The following is a description of a gene set: species: Homo sapiens Human Gene Set: GOBP_REGULATION_OF_CELL_DIFFERENTIATION Any process that modulates the frequency, rate or extent of cell differentiation, the process in which relatively unspecialized cells acquire specialized structural and functional features., and this is the list of marker genes: MME, WIF1, SLC45A3, ABCB10, ACTL6B, MEDAG, GNB3, MTA3, NUMA1, RFLNB, DDRGK1, NKX2-5, JDP2, LOXL2, PNP, CAPRIN1, NEUROD1, GPS2, MIR573, GDPD2, MT3, TSPO (NCBI Gene Id 706), HGF, BNIP2, ZDHHC21, PRAMEF26, KLF4, HES2, HDAC9, EPHB1, PRKX, CLIC1, PRUNE1, TNFRSF12A, RBPMS2, UCMA, BCL7B, PRAMEF4, BMPR1A, MIR3648-1, NR1D2, HIF1AN, OVOL2, BOC, LAMB2, CLDN5, HSPA1A, NFE2L1, ETV4, JUNB, LIMD1, VNN1, ATF4, MAP2K2, SLC6A4, CDKN1B, CDH5, ARID1A, PLAAT4, IL23A, ANXA2, NPHP3, TRIM16, PTBP1, LPAR3, SIRT6, ALOX5, MIB1, FSHB, XDH, IL1B, POU4F1, SRRT, MACROH2A2, PAEP, TREM2, DRAXIN, SOCS2, BTG1, AGT, ADRA2B, NANOG (NCBI Gene Id 92937), MAP2K1, GAS6, PRAMEF15, CDH4, SUCO, SYT4, ARID2, RTN4, FBN2, NKX3-2, SPAG9, CREB1, TNFRSF11A, GLUL, PTH, MIR130A, MIR138-1, FOXA2 (forkhead box A2), SART1, DKKL1, LRP5, BRINP2, EFNB3, LRRC8A, FOS, ANP32B, PIAS3, ABCB1, DMRTA2, LNPK, INHA, PITHD1, FXR1, OPA1, PDPN, CCR1, CAV1, ALX1, NEUROD2, ZNF536, PSEN1, PRAMEF9, SOX2, CR1, RNF41, PWP1, RNF112, ABCA12, H4C1, SLC7A10, FOXG1, KIF14, SAV1, CHD7, HES5, SPINK5, SMAD4, SFRP4, ZFHX3, WEE2, EDNRB, CHODL (NCBI Gene Id 84535), MAMSTR, LRP4, KLK6, PIK3R1, SMAD6, SIK1, ESRRB, LGALS1, BRINP3, METTL14, PPP2R3C, EGR2, DPYSL5, PLA2G5 (phospholipase A2 group V), TENM4, MYOG, ZNF488, S1PR3, SOX9, ISL1, MIR19A, EPO, EDN3, SPINT1, CDK5 (cyclin dependent kinase 5), ENG, CTR9, BRD2, NBL1, RB1, CD80, RPL3L (ribosomal protein L3 like), DPF2, FOXO4, LDLR, HMGB3, MAP3K13, E2F1, P4HTM, FBXW8, NKX2-2, SUZ12, RECK, GREM1, MTA1, ROCK2, TGFB2, SMARCA2, FSHR, AGTR1, CDK12, DDR2, N4BP2L2, GCNT2, MIR107, CCDC85B, MYC, ADIPOQ, SMYD1, BCL7C, F11R, FRZB, DACT3, RORA, SERPINE2, GPC1, IL7, ITCH, FOXP3, DCT, BLOC1S5, GSK3B, ZC3H12A, SMARCE1, TRPC5, SEMA3G, H4C12, MIR15B, TMEM100, SOX1, MIR204, NPPC, MIR150 (NCBI Gene Id 406942), TESPA1, CSF3R, CITED1, SOX3, BMP6, NEUROG3, NLRP3, NME2, STK11, CYP26B1, ZNF16, TBX5, TFAP2B, HTR2A, NACA, FSTL3, USF3, FUOM, WNT3A, SOD1, SLITRK1, LRG1, BRPF1, PLXNA3, PTN, EIF4G1, PSG9, NPR2, MIR146A, INS, ADAMTS7, YAP1, SFN, BNC1, SMYD5, IST1, CDKN2A, CASZ1, FEZF1, LTF, DIXDC1, WNT5A, CAPN3, PARP2, BCL6, PTPRS, ACVR2B, SERPINF2, MIR106A, PRAME, PDE3A, SLC9B2, MIR214, RASGRP1, CTNNBIP1, ZBTB16, SLAMF8, SKI, TBC1D24, FGFR1, MEGF10, CELA1, TRIO, MAN2A1, MIR34A, PI16, CXCL12, CYP27B1, ITGB3, PRMT6 (protein arginine methyltransferase 6), RBBP4, ARRB2, HPN, DDX6, CIB1, WDFY2, CCL3, RASSF2, PRAMEF18, TNF, SOX4, CARM1, UQCC2, EEF2K (NCBI Gene Id 29904), MMP11, CDKL5, AXL, CTDP1, TGIF2, VSX2 (visual system homeobox 2), BMP7, TCIRG1, L3MBTL1, FES, CX3CR1, HSPA9, FRS2, TLR9, ADGRV1, RFX3, TMEM98 (NCBI Gene Id 26022), PRAMEF7, ETS1, SLIT2, HSPA1B, NUMB, MTOR, FGF8 (NCBI Gene Id 2253, fibroblast growth factor 8), LIG4 (NCBI Gene Id 3981), BATF, MYOD1, MIR19B1, MYCN, TNFRSF1B, LRP2, GDF5, PPP1R13L, CHRD, PRAMEF10, TGFB3, PDCD4, ZFPM2, PTPRD, MSTN, CDON, ROBO1, ARHGEF2, IGFBP3, CCN6, IL21, TFAP2A, TP73, IGFBP5, SOCS1, CTH, PRKD1, STAU2, SASH3, MIR99B, FLCN, GRN, HSF1, MIR185 (NCBI Gene Id 406961), PLCB1, NOTCH4, KLF10, GDF7, PAF1, TRIM58, LPL, NFKBIA, COL5A2, PTEN, OCSTAMP, WNT7B, NR5A2, FBN1, HLTF, TARBP2, BMP4, TUNAR, POU3F2, ZEB1, MIR424, PIK3R6, SCUBE3, PRAMEF13, FCGR2B (NCBI Gene Id 2213), MALT1, TLX2, LHX2, IL17A, MIR1-1, FOXJ1, CCL8 (NCBI Gene Id 96488), TGFB1I1, HAND2, NFE2L2, TOB2, KRT84, NR6A1, MEAF6, GPRC5B, LTA (NCBI Gene Id 4049), FANCD2, DSPP, PAX8, CCN3, RUNX2, SMAD5, SPRR5, RGS14, STAT5B, BLTP1, MIR9-1, AJAP1, FBXO7, NRARP, H4C15 (NCBI Gene Id 724021), NTN1, TNR, MPL, IL12RB1, TP53 (tumor protein p53), TTBK1, GPER1, TTPA, EFEMP1, CDS1, RHOA, RAB21, MIR511, MYCL, DHX36, PRAMEF5, RC3H1, IL27, CNOT4, CCDC3, ZNF703, ATOH8, BMP10, GDI1, LTBP3, PRAMEF2, IQCB1, SORT1, STAT3, STAT5A, GJA1, SOS2, LBX1, LILRB3, CCN5, SNAI2, CARTPT, TMPRSS12, ING5, CLDN18, IFNL1, BRAF, PGLYRP2, IFNB1, MTCH2, MDK, MIR17, FGF20, GLG1 (golgi glycoprotein 1), PRKCZ (protein kinase C zeta), PRAMEF19, CDH1, RND2 (Rho family GTPase 2), LGALS3, STK3, ZMIZ1, MIXL1, PHOX2B, NEDD9, ZFHX2, PRDM1, MIR200C, CUX2, CDK9, SOCS5, GDF6, FGF10 (fibroblast growth factor 10), SPI1 (Spi-1 proto-oncogene), ACVR1, OLIG2, CRP, TOMM70, PUS7, CUL7, SIX2 (SIX homeobox 2), GLI3, ACTB, NRG1, MIR17HG, PBX1, PIEZO1, RPS6KA3, KAT6B, RCOR1, RORC, AMIGO1, ITGAV, IL4I1, ABL1, RAC1, TRPV4, LRRC17, SRSF6, SLC4A2, MEX3C, MYSM1, DYNLT1, ANAPC2, DRD2, TRIM11, RIPK1, TCF3, NGF, GDF3, CRTAM, STK25, DMD, PLEKHB2, EIF2AK4, MIR495, TRPV2, SOX8 (NCBI Gene Id 30812), KHDC3L (NCBI Gene Id 154288), OR10J5, ZFP36L2, ESRP1 (NCBI Gene Id 54845), TNFSF4, NFATC1, CLEC7A, SULT2B1, CSF2, IFITM1, ZAP70, MIR103A1, H4C3, DDX5, APOB, HDAC5, BMP8B, TWF2, ADRA2C, POR, H4C13, NEUROD4, SPOCK2, GPR65, BBS12, FOXA1, SDHAF2, NELL1, LOX, PRKACA, HCLS1, MAPK11, RARA, APLF, ZFP36 (ZFP36 ring finger protein), ISL2, TWIST2, THPO, FBXO11, VEGFC, CBFB, ETV5, FZD3, BCL2, MIR137, MIR22, PPP1CC, DSG2, NEUROG1, DAG1, FZD1, SHANK3, BTN2A2, MIR181A2, CDK5R1, MIR93, ADGRA2, SOX17, PTGS2, ADIRF, TGFBR2, GDF11, RGS4, NPTN, SMARCD3, IAPP, JUND, MIR20A, PLA2G10, SOCS3, TGIF1, CEBPD, RBM38, SIN3A, SEMA4F, TSC22D1, TCF15, RGMA, GDF2, CDX2, RELN, BTG2, MAP1B, BCL6B (BCL6B transcription repressor, NCBI Gene Id 7613), CDK5RAP2, TRIB1, IL2RG, DTX1, ADM, CAMK2B, TERT, MIR342, PRAMEF20, SETD1A, HOXA7, FOSL2, DLL4, PLA2G2A, PROC, MMD, MIR206, SERPINB3, HLA-DRA, RC3H2, ZBTB7B, MEF2C, TAF8, WNT1, PKP1, TRIM72, C1QL4, RHEB, ZBED6, SORL1, METRNL, ITPKA, FOXP1, PLPP7, ANKLE1 (ankyrin repeat and LEM domain containing 1), DUSP15, HDAC1, DROSHA, HLA-DOA, MIR27B, KAT5, PTCH1, RIN2, VDR, ANKRD27, VSTM2A, RAPGEF2, EIF2AK2, UBASH3B, ULK1, MSX2, CMKLR1, PRAMEF33, YPEL4, CEBPA, AURKA, TGFB1, PF4, OTP, RUNX1T1, DRD3, NAPEPLD, PCK1, LAMB1, IRF4, ASCL2, AR, ILK, CCR2, HMGB1, EZH2, IKZF3, NOS1, GOLGA4, ARHGAP4, AKIRIN2, IL1RAPL1, CNTN2, TP53INP1, UNCX, ARID1B, LHX1, IL1RL2, VSIR, LEP, TCF7, ZNHIT1, CTNNB1, H4C2, EVI2B, SETD3, NKX6-1, ZHX3, KDM3A, TBX6, PRMT5, H4C8, GSK3A, F2, XBP1, FAM20C, MAF, MAPK14, SPEN, TCF23, WNT10B, TNPO2, CCL19, MBNL3, BRD9 (bromodomain containing 9), YY1, IL4, CXCL9, XRCC2, MED28, PAX2, MYOCD, SMARCC1, FZD4, TSKU, IL5, RBPJ, MIR518B, MAFF, DAB2IP, RHEX, BCL11B, DLL3, KLHL25, AQP3, AXIN2, HES6, PPP3CA, ERBB2, CDK13, MIR30B, DNMT1, NCKAP1L, DAB2, MYB, MECP2, CDK6, CLEC12A, FBXW7, UFL1, MIR98, TNFSF11, ADD1, MYLK3 (NCBI Gene Id 91807), CEACAM1, IL17D, PLA2G3 (NCBI Gene Id 50487), CSF3, LILRB4, CERS2, NRDC, TRAK2 (NCBI Gene Id 66008), RIPOR2, FANCA, KAT2A, HOXB8, DAB1, NFKBIZ, MIR221, BTK, FAM210B, HOXB3, ERFE, SIRT1, ZFYVE27, ITPKB, H4C11, WNT3, CALCA, PRKCA, TWSG1, SLIT1, HOXB4, SMAD2, VWC2L, RIPK2, HEY1, DMPK, RBM15, IGF2, MEIS1, XRCC5, DDIT3, ENPP1, PRTG, MITF, PTHLH, OPRM1, HOXA2, TMEM64, C1QC, EIF6, TWIST1, YBX1, TIAM1, MSR1 (macrophage scavenger receptor 1), PLXNC1, PGLYRP3, SPRY1, MAG, FOXN1, GPR137B, RPS6KA1, CLPTM1, S100B, LDLRAD4, HES1, LMO3, HOXA9 (NCBI Gene Id 94575), BRPF3 (bromodomain and PHD finger containing 3), PRLR, FERD3L, RASSF10, HTR2C, GATAD2B, ABCG1, TMEM178A (transmembrane protein 178A), TCF7L2, ID3, MIR18A, FOXO1, FLOT2, SIX3, NOG, KDF1, AKAP6, COL1A1 (collagen type I alpha 1 chain), RCAN1, ISLR2, PLXND1, CCND1, ZBTB46, RAMP2, PPP1R12A, METTL3, CD2, ZHX2 (zinc fingers and homeoboxes 2, NCBI Gene Id 22882), KLF13, HOXA11, PKDCC, OPALIN, IL20, BMPR2, CXCR4, HMGA2, SOX11, MEN1, ST7, CXCL10, INSIG1, BRD7, PRAMEF27, MMP14, IL2RA, BMAL1, UPF3B, H4C14, MIR590, SUPT6H, SDCBP, FADS1, LIN28A, GFI1B, CUL4A, PTGR3, MYF5, BAMBI, LEF1, RAP1A, PRAMEF17, NUMBL, RANBP3L, PPP2CA, GATA3, GCM1, FNDC5, LIMK1, HEMGN, KITLG, CUX1, NAP1L2, MCRIP1, SKIL, TNFSF9, H4C16, RARG, FOXC1, ZBED2, RGS2, BICRAL, VCL, APOLD1 (apolipoprotein L domain containing 1), TNFAIP6, NKX6-2, VHL, CDK5RAP1, ZC4H2, ALOX15B, NFKBID (NFKB inhibitor delta), SMARCD2, ABCA1, WNT4, GDPD5, HLX, DAAM2, RBM24 (NCBI Gene Id 221662), ANXA1, MIR302A, APP, HMG20A, QKI, PIM1 (NCBI Gene Id 82453), LGALS9, WWTR1, PRAMEF1, CD69, BRD4, L1CAM, NEPRO, SIX4, CEBPB, OLFM1, MEGF8, HOPX, NRP1, MIR100, SRF, HLA-B, PRKG2, PRDM6, DSCAM, NKX6-3, NIN, SNAI1, SIGLEC15 (NCBI Gene Id 284266), NEFL, EXTL3, CX3CL1, MIR200B, MAPK9, PTK2B, PLXNB3, PIAS1, TBX1, EREG, EDN1, LILRB1, MIR18B, ECT2, BAIAP2, MMD2 (NCBI Gene Id 221938), JAK2, MIR199A1, GFAP, HDAC7 (histone deacetylase 7), TMEM176A, SHH, MDM2, MICOS10-NBL1, SMARCD1, SEMA5A (NCBI Gene Id 9037, semaphorin 5A), CCNT2, PPARD, HEYL, CD86, MIR208A, FOXO3, EID2B, MIR302B, BRD1, RUFY3, PLEKHB1, TMEM182, LTK, ACVRL1, PARP1, KCNK18, ID2, SOX10, NELFB, ZFP36L1, BGLAP, RBM4, CARD11, ULK2, AMBRA1, SMURF1, AHI1, ADAMTS20, CD4, DUSP10, SOSTDC1, SMOC1, TRPS1, ZNF268, RUNX1, PRAMEF25, REST, DLL1, VEGFA, HEY2, EFEMP2, SERPINE1, RGCC, DISC1, MIR205 (microRNA 205), MIR320A, MYF6, TRIB3, BMPR1B, BHLHE40, MAML1 (mastermind like transcriptional coactivator 1), IL12B, CYLD, GRM5, TP63, HES7, H4C9, GATA1, HIF1A, DUOXA1, EFNB2, PRKCH, RFLNA, FGF18, VEZF1, ZNF750, MYRF, WNT7A, IL13 (NCBI Gene Id 96500), TCP11, BEND6, IGF1, RAP1GAP, FGF2, TRIM62, ACTL6A, DPF3, CREBL2, IHH, DOCK7, LAMA2, ARMCX5-GPRASP2, CCN2, PKP2, HDAC4 (histone deacetylase 4), PRDM16, ID4, VAX1, ABCC8, HOXA5, TNFSF18, PRELID1, WDR1, MIR199B (microRNA 199b), MAPK1, MIR29B1, SLC30A1, AP3B1, TNFRSF11B, ASB4, RREB1, CHD4, HELT, H4C4, YTHDF2, IPO7, MIR133B, LAG3, MIR379, CTHRC1, FGFR2 (NCBI Gene Id 2263), METRN, SFRP1, CCN1, SMARCA4, SMARCC2, SHOX2, TYROBP, S1PR2, AGER (NCBI Gene Id 177), CD34, ANKRD26, MUSTN1, CD74, SLC7A5, HMGB2, PRAMEF22, SPRED2, ISG15, IL4R, ZBTB1, TMEM176B, FOXE3, GORASP1, KIT, PRAMEF8, ACIN1, S100A10, NFATC3, TRPC6, FTO, PTPRQ, SPP1, RAC3, SMO, MIR486-1, PAX6, PARP6, PTBP3, IL34, HAX1, NR2E1, LMX1A, PRAMEF6, FGF13, INPP5D, SHTN1, HNRNPU, TAOK3, JAK3, NLN, CCL11, TCTA, MIR10A, POFUT2, IFNA2, TLR4, MIR26A1, INHBA, BRINP1 (BMP/retinoic acid inducible neural specific 1), SPSB3, DNAJB11, XKR8, GPR137, IL17RD, TFE3, PTPN2, XRCC6, APPL2, MSX1, CPNE1, BCL11A, CLCF1, PPARGC1B, SOX5, HSP90AB1, ANKRD2, CCN4 (cellular communication network factor 4), GLIPR2, RARRES2, EP300, AAMDC, ZNF335, MIR140, HLA-DRB1, TPH1, FERMT2, TM4SF19, SPART, ITGB1, ELL3, ID1, FGF9, TNFSF14, GATA5, SINHCAF, ARNT, PTPRC, FADD, DNAI3, VWC2 (von Willebrand factor C domain containing 2), LOXL3, DKK1, MCUB, IL2 (NCBI Gene Id 3558), FBXO22, PER2, SLC46A2, IRF7, FSTL4, CRIM1, OSR1, MIR133A1, SIRT2, EPHA3, FBXO5, ROBO2, CYB5D2, ADAM7, NDFIP1, ZC3H8, MAP3K5, MIR145 (microRNA 145), DDX17, CTLA4, TNFRSF1A, IL6R, EEIG1, TCF4, CMTM5, EMP2, TIAM2, MIR499A, MEIS2, GDF10, GDNF, ZBTB7C, MIR202 (NCBI Gene Id 574448), PRMT3, THY1 (Thy-1 cell surface antigen), MIR142, CTDSP1, TNFRSF21, CAMK1, KIAA0319, BDNF, PLXNB1, ETV2, ATAT1, MTA2, KDM1A, MIR181B1, CALR, EYA1, SS18, RPS19, WNT5B, LEO1, CTNNA1, YWHAH, PRKCI, IL15, SP7, HMG20B, PTK2, PRXL2A, NR1H2, RORB, MIR149, RNF6, CDKN1C, SMARCB1, VASN, PHF10, FGL2, CDC73, RHOH, SRA1 (NCBI Gene Id 10011), CNTF, BCL9L, AKIRIN1, IL10, ALK, SMAP1, NTRK3, TMEM131L, RAB37, SYNGAP1, ZNF365, TEAD2 (TEA domain transcription factor 2), ANKRD54, GPRASP3, CRB2, EIF4E, MBD3, FOXJ2 (NCBI Gene Id 55810), SERPINF1, CFL1, NFAM1, NBR1, PTPN11, ASXL2, MACROH2A1, NR1D1, NOCT, SPRY2, DLX2, NFATC2, DBN1, SMAD3, STK4, PGLYRP1, APCS, CNTN4, TCFL5, NPNT, RAG1, ZNF219, TRAF6, BCL7A, DLX1, PPARA, TRIB2, TOX, DIP2B, GHR, NOTCH3, KRT36, H3-4, PDGFB, OBSL1, GPR55, ASPM, FMR1, KDR, PTPRZ1, GNA11, SEMA6D, NFATC4, PPP2R1A, ADA, BTC, PAK1, NID1, CD46, FST, NLGN1, ABCA5, ATP11A, KIFAP3, SOX13, ZNF385A (NCBI Gene Id 25946), GLI2, ADAM8, NF1, FUZ, DPF1, BIRC2, CEACAM5, LSM1, IL23R, IL18, TENT5C, TESC, SH3GL3, IL6ST, EFNA1, IL15RA, EFNA5, KEAP1, BMP2, TOB1, TLCD3B, SPRED3, ERRFI1, SMAD7, DICER1, CHD3, IL6, PDCD2, LCK, KAT8 (lysine acetyltransferase 8), ADIPOR1, NSUN2, DCC, SHB, MIR21, ASCL1, ADAMTS12, CAV3, MIR125B1, SH3RF1, MAFB, CD109, TCP11X2, BMP5, BHLHA15, TRIM32, RBBP7, WDR62, LIF, SEMA3F, TGFBR1, NCOA1, G6PD, OCIAD1, TRAK1 (NCBI Gene Id 22906), LAMA1, CD27, SUFU, MIR20B, NAP1L1, KAT6A, SENP1, ATOH1, CETP, MIR223, PRDX2 (peroxiredoxin 2), FGF23, ATRAID, RPTOR, HOXD3, SGPP1, NR1H3, RELA, ASXL1, TBX21, IRX3 (iroquois homeobox 3), TACSTD2 (tumor associated calcium signal transducer 2), CD24, MIR675, FN1, ATXN1, SLC6A6, LMOD3, HES3 (hes family bHLH transcription factor 3), CAMK4, RAG2, STAT1, LILRB2, SOD2, MIR222, CDKL3, POU4F2, KLF7, LAMC1 (laminin subunit gamma 1), NOTCH2, SULT1E1, DLK2, NOTCH1, TAL1, MIR128-1, MACF1, FCRL3, CASP8, SIX1, SFRP2, INSM1, TCP11X1, GABPA, TCIM, RTN4R, ADNP, PRAMEF11, NF2, PRAMEF14, MARK1 (NCBI Gene Id 55887), CD36, CHADL, WNT9B, SMAD1, GRHL1, PTCH2, MBOAT2, GLI1, RAB7B, JAG1, RUNX3, MIR448, MIR548D1, ACVR1B, MESP1, PLXNB2, SLC4A11 (solute carrier family 4 member 11), PCP4, PPARG, SKIC8, BAD, TENT5A, KCTD11, TRPM4, SOS1, REG3G, HDAC3, OSM, SYAP1, PRICKLE1, ELF5, ADCY10, SNW1, KDM4C, RAF1, ADIG, HDAC6, HLA-G, EPHA7 (EPH receptor A7), NFKB1, CAPRIN2 (caprin family member 2), IMPACT, PA2G4, TMSB4X, LBH, EPHA4, NRCAM, BIN1, AREG, CSF1, IFNG, PRMT1, PROX1, WNT9A, IKBKB, PRAMEF12, SOX6, GPR37L1, CLOCK, GPR68, RARB, MIR27A, MIR210, SEMA4D, SPRED1, MIR372, TRIM46, SEMA7A, PTPN6, EGFR, PITX3, MAD2L2, MIR130B, NODAL, PBRM1, YWHAG, CDK1, HOOK3, DISP3, MAPT, KRAS, NREP, MIR181C, PCM1, MAP2, FXR2, RIOX1, NMRK2, IL7R, SCIN, NUDT21 (nudix hydrolase 21), TGM2, CSRP3, H4C5, DCSTAMP, MIR203A, H4C6, CLEC4G, IFRD1, MIR144 (microRNA 144), ZEB2, IL36B, LRP8, MOSMO, KAT7, ACVR2A, NEURL1, KLF5, ROCK1, EPHB2, ZNF675, TCF12, PAFAH1B1 (platelet activating factor acetylhydrolase 1b regulatory subunit 1), AKT1, RYK, OLFM2, ZFPM1 (zinc finger protein, FOG family member 1), BHLHE41, CD83, PROM1, LYN, TLX3, RNF10, GATA2, ADAMTS9, CDK5RAP3, HAP1, EIF4ENIF1, ZNF683, PDGFRA, SPDEF, NKX2-1, AXIN1, PCID2, CRABP2, TBX19, GATAD2A, MTURN, NCOA3, TBX20, FAXDC2 (fatty acid hydroxylase domain containing 2), REG3A (NCBI Gene Id 5068), TRIP4, PRKDC (protein kinase, DNA-activated, catalytic subunit), WNT2, CD28, GSX2, TBX3, TMEM53, SYK, IRF1, NTRK2, HDAC2, FZD7, B2M, FEZF2, ACTN3, MAFG, CD101, PURB, LDB1, BICRA, SEMA6C, OSTN, COL5A1, CLCN2, RRAS (NCBI Gene Id 6237), EGR3, FNIP1, PLAG1, MAP6, TNXB, BLOC1S6 (biogenesis of lysosomal organelles complex 1 subunit 6), SHOC2, MAPK12, LRP3, MIR24-1, LRRK2, NKAP, MIR519D, FFAR4, MED1, TLR3, GPR171, AP3D1, MCF2, IDH2 (NCBI Gene Id 3418), MIR483, SOX12, KLHL41, TRIM6, USH2A, SS18L1, TMEM119 (transmembrane protein 119), MMP9